The following is a description of a gene set: An abnormality of eye movement characterized by impaired smooth-pursuit eye movements. studied in species Homo sapiens Abnormality of ocular smooth pursuit Human Gene Set: HP_ABNORMALITY_OF_OCULAR_SMOOTH_PURSUIT, and this is the list of marker genes: RFC1, PDHB, PAFAH1B1, TTBK2, STT3A, KCND3, GNB1, ALS2, PRDX3, MRE11, FMR1, ATN1, SPTBN2, XRCC4, ATXN10, TMEM106B, CACNA1A, TPP1, TMEM216, EEF2, TULP1, RNF170, TBCD, ATXN2, PRKCG, ELOVL4, TMEM240, PLA2G6, ANO10, FGF14, PIK3R5, POLR3B, DARS2, PEX10, STXBP1, MAN2B1, TSEN54, DPM2 (dolichyl-phosphate mannosyltransferase subunit 2, regulatory), ZFHX3, SYT14, GJB1, THG1L, ATXN3, UCHL1, STUB1, ENSG00000288330, PLD3, PRNP, SPG11, GBA2, KCNC3, NOP56, WARS2, SYNE1, GDAP2, FTL, ZFYVE26, ATXN8OS, RARS1 (NCBI Gene Id 84715), RUBCN, ITPR1, TBP, KCNN2, SACS, AARS1, SCYL1 (SCY1 like pseudokinase 1), ATP2B3, CACNA1G, POLR3A, INPP5E, XRCC1, PMPCA, ATXN1, SETX